The following is a description of a gene set: Human Gene Set: GOBP_POSITIVE_REGULATION_OF_LIPID_METABOLIC_PROCESS Any process that activates or increases the frequency, rate or extent of the chemical reactions and pathways involving lipids. studied in species Homo sapiens, and this is the list of marker genes: NR5A2, ADM, CES1, TNFRSF1A, SCARB1 (NCBI Gene Id 949), LPGAT1, NSMAF, ABCD2, MLST8, AGT, CREBL2, CNEP1R1, DISP3, GDF15, AADAC, LDLR, SLC27A1, ZBTB20, PPARGC1A, ABCG1, ABCD1, APOA2, INS, MIR96, PLIN5, DAGLB, GHSR, ABHD6, PTGS2, TAFAZZIN, LDLRAP1, TNF, APOA4, ELOVL5, SORBS1, ADIPOQ, POR, SCP2, APOA1, CD74, HTR2C, ABHD5, CGA, APOH, PLA2G6, SIRT4, MTOR, PRKCD, PRKAA1, SLC45A3, IL1B, RPTOR (regulatory associated protein of MTOR complex 1), KAT5, CREB1, MAPK1, SCT, SCAP, KLHL25, WNT4, HTR2A, PCK1, DAB2, MLXIPL, CCDC3, CCN1, CLSTN3, AVP, PLA2G3, PPARG, FSHB, STARD4, STAR, NR1D1, ADGRF5, NR1H3, HSD17B13, XBP1, OGT, TWIST1, CYP7A1, IFNG, FUT1, QKI, NR1H4, PLAA (phospholipase A2 activating protein), CAPN2, SPATA18, AKT2, PPARA, AKT1, SREBF2, CTDNEP1, MLYCD, RDH10, GPIHBP1, SREBF1, DGAT2, CHP1, KPNB1, PRKCE, MID1IP1, SIRT3, PPARD, FABP3, ZNF750, MTLN, MIR29B1, KAT2B, IRS2, HTR2B, RAB38, ENPP7, PNPLA2, IRS1 (NCBI Gene Id 3667), ABCG4, ANGPTL3, SIRT2, NR1H2, MFSD2A, GNAI1, EEF1A2, MIR182, ACSL3, AGTR1 (NCBI Gene Id 9449), APOE, PRKACA, GPLD1, APOA5, AVPR1A, PAQR3 (NCBI Gene Id 152559), APOC2, CPT1A, BMP6, MBTPS2, ADORA1, FGF1, SPHK2